The following is a description of a gene set: Human Gene Set: REACTOME_NEF_MEDIATED_CD4_DOWN_REGULATION Nef Mediated CD4 Down-regulation studied in species Homo sapiens, and this is the list of marker genes: AP2M1, LCK, AP2A2, AP2B1, CD4, ATP6V1H, AP2S1, ARF1, AP2A1